Given this list of marker genes FGFR2, ANLN, GBE1, PARD3B, SLC66A3, KCTD20, ERCC6, KCTD9, NPAS3, SCAMP1, USP15, PROX1, TDG, CHN2, VAT1L, ZNF736, MAST4, SLC15A2, CROT, FAT3, KLHL29, MBD2, OTUD7B, DACH2, YOD1, ZNF257, ITPA, SPOPL, FBN2, KCNH5, MGAT4A, ZCCHC2, NF1, TNFSF11, NAP1L2, YTHDC1, RBSN, TMA16, KLF12, LMO7, SCN9A, MAMDC2, BCL11A, GTF2H2, USP27X, EZH2, CORO1C, CTNNB1, ATG7, TMEM68, HIPK3, LINC03042, FOXL2NB, CCNYL1, CDYL2, PRKAR2B, ZNF92, ATF1, SH3PXD2A, FRMD5, POLD3, WDR48, ZNF708, PPM1F, AGFG1, GKAP1, ADGRG6, REST, GPM6A, SEC23IP, AGO4, HSPA9, VSNL1, UBL3, G6PC1, NEXN, RAP2C, ASAP1, LIN9, DDX53, ZCCHC4, ZNF721, NDN, HS3ST3A1, TMEM65, DACH1, BICC1, RAB4A, POGLUT2, RUNX2, TMTC4, DNAJC5, ADGRB3, LEPR, FAM98A (family with sequence similarity 98 member A), WNT3, PTPN21, ATP11C, MRE11, HNF1B, ASXL3, GRIK2, APPBP2, FNDC3B, RAPGEF6, TOGARAM1, PANK1, ATP1B1, DACT1, TUBB6, PPM1D, G3BP2, DMRT2 (doublesex and mab-3 related transcription factor 2), C5orf24, KATNA1, DOCK4, SEMA3A, SLC25A27, TXNDC16, COX18, RIMS2, PDE12 (phosphodiesterase 12), NFAT5, MTERF3 (mitochondrial transcription termination factor 3), TIAM2, LRP6, PSIP1, WAPL, MYEF2, PCNA, ACVR2B, CHST11, CUL5, STT3A, TLK1, ATP9A, DISC1, ACER3, RBFOX1, CA8, TDO2, KCNJ6, ATP8A1, ANO3, ZNF680, C18orf63, PPM1A, KPNA4, SOS1, PICALM, SLC38A2, MPHOSPH9, CREB5, LPAR1, NAB1, KRAS, TEX101, MTTP, ELOC, RPL13, RHOT1, EFHC2, KIAA0408, FAM169A, TTC28, MIER3, SLC4A4, NUP214 (nucleoporin 214), CILK1, NIPBL, TACC2, DNA2, CHPF, PPP4R2, ASXL1, GXYLT1, DOCK3, ANP32E, ALDH16A1, ZBTB24, ST8SIA6, AAK1, HIVEP3, NSUN3, URB2, BDKRB2, RTF1, here is a description of the gene set: species: Homo sapiens from publication Chen Y, Wang X (PMID 31504780) Human Gene Set: MIR217_5P Genes predicted to be targets of miRBase v22 microRNA hsa-miR-217-5p in miRDB v6.0 with MirTarget v4 prediction scores > 80 (high confidence targets).